The following is a description of a gene set: Human Gene Set: SETLUR_PROSTATE_CANCER_TMPRSS2_ERG_FUSION_DN from publication Setlur SR, Mertz KD, Hoshida Y, Demichelis F, Lupien M, Perner S, Sboner A, Pawitan Y, Andrén O, Johnson LA, Tang J, Adami HO, Calza S, Chinnaiyan AM, Rhodes D, Tomlins S, Fall K, Mucci LA, Kantoff PW, Stampfer MJ, Andersson SO, Varenhorst E, Johansson JE, Brown M, Golub TR, Rubin MA (PMID 18505969) BACKGROUND: The majority of prostate cancers harbor gene fusions of the 5'-untranslated region of the androgen-regulated transmembrane protease serine 2 (TMPRSS2) promoter with erythroblast transformation-specific transcription factor family members. The common fusion between TMPRESS2 and v-ets erythroblastosis virus E26 oncogene homolog (avian) (ERG) is associated with a more aggressive clinical phenotype, implying the existence of a distinct subclass of prostate cancer defined by this fusion. METHODS: We used complementary DNA-mediated annealing, selection, ligation, and extension to determine the expression profiles of 6144 transcriptionally informative genes in archived biopsy samples from 455 prostate cancer patients in the Swedish Watchful Waiting cohort (1987-1999) and the United States-based Physicians(') Health Study cohort (1983-2003). A gene expression signature for prostate cancers with the TMPRSS2-ERG fusion was determined using partitioning and classification models and used in computational functional analysis. Cell proliferation and TMPRSS2-ERG expression in androgen receptor-negative (NCI-H660) prostate cancer cells after treatment with vehicle or estrogenic compounds were assessed by viability assays and quantitative polymerase chain reaction, respectively. All statistical tests were two-sided. RESULTS: We identified an 87-gene expression signature that distinguishes TMPRSS2-ERG fusion prostate cancer as a discrete molecular entity (area under the curve = 0.80, 95% confidence interval = 0.792 to 0.81; P <.001). Computational analysis suggested that this fusion signature was associated with estrogen receptor (ER) signaling. Viability of NCI-H660 cells decreased after treatment with estrogen (viability normalized to day 0, estrogen vs vehicle at day 8, mean = 2.04 vs 3.40, difference = 1.36, 95% CI = 1.12 to 1.62) or ERbeta agonist (ERbeta agonist vs vehicle at day 8, mean = 1.86 vs 3.40, difference = 1.54, 95% CI = 1.39 to 1.69) but increased after ERalpha agonist treatment (ERalpha agonist vs vehicle at day 8, mean = 4.36 vs 3.40, difference = 0.96, 95% CI = 0.68 to 1.23). Similarly, expression of TMPRSS2-ERG decreased after ERbeta agonist treatment (fold change over internal control, ERbeta agonist vs vehicle at 24 hours, NCI-H660, mean = 0.57- vs 1.0-fold, difference = 0.43-fold, 95% CI = 0.29- to 0.57-fold) and increased after ERalpha agonist treatment (ERalpha agonist vs vehicle at 24 hours, mean = 5.63- vs 1.0-fold, difference = 4.63-fold, 95% CI = 4.34- to 4.92-fold). CONCLUSIONS: TMPRSS2-ERG fusion prostate cancer is a distinct molecular subclass. TMPRSS2-ERG expression is regulated by a novel ER-dependent mechanism. studied in species Homo sapiens Genes down-regulated in prostate cancer samples bearing the fusion of TMPRSS2 with ERG., and this is the list of marker genes: KLHL21, ITGAD, PNLIPRP2, PROM1, ADH5, AADAC, ALOX15B, FOXF2, RGS7, GRK1, AQP2, RAB27A, MPPED2, TMT1A (NCBI Gene Id 25840), HPS1, CCR1, NEUROD1, CSDC2, AMELX, TRO